The following is a description of a gene set: Genes predicted to be targets of miRBase v22 microRNA hsa-miR-509-3p in miRDB v6.0 with MirTarget v4 prediction scores > 80 (high confidence targets). Human Gene Set: MIR509_3P studied in species Homo sapiens from publication Chen Y, Wang X (PMID 31504780), and this is the list of marker genes: ENO4, SLC37A2, SH3GL3, CDK17, RNF130, RAD9A, ENTPD3, USP27X, MLF1, SERPINB9, NETO2, TRPA1, LRRC39, COCH, MMD2, RBMY1F, RAB5C, BRWD1, RBMY1E, ST3GAL2, TCF7L2, CLXN, PLGRKT, RIBC1, ERVW-1, VGLL4, LRRTM1, CALB1, CACNB4, SORD, SCG3, COG5, PRUNE1, RFX3, MDH2, JADE1 (jade family PHD finger 1), YAP1, PSD3, MAP3K8, KDF1, VEZF1, XPR1, NR1D2, PLP1, ANKRD23, MCFD2, RNF180, SF3B4, PIP5K1B, ZNF423, ZMAT3, MMP19, DDAH1, KATNBL1, UNC13B, FAM240A, CES3, VPS26A (NCBI Gene Id 96725), HABP4, OSBP, ZNF345